Given this list of marker genes CITED2, CITED1, YEATS4, TFAP2D, CREBBP, WWOX, EP300 (E1A binding protein p300), TFAP2B, TFAP2A, CITED4 (Cbp/p300 interacting transactivator with Glu/Asp rich carboxy-terminal domain 4), TFAP2E, TFAP2C, here is a description of the gene set: Activation of the TFAP2 (AP-2) family of transcription factors Human Gene Set: REACTOME_ACTIVATION_OF_THE_TFAP2_AP_2_FAMILY_OF_TRANSCRIPTION_FACTORS species: Homo sapiens